The following is a description of a gene set: Any process that stops, prevents, or reduces the frequency, rate or extent of TOR signaling. species: Homo sapiens Human Gene Set: GOBP_NEGATIVE_REGULATION_OF_TOR_SIGNALING, and this is the list of marker genes: PRKACA, SPAAR, ATXN3L, GSK3A (NCBI Gene Id 2931), PRKAA1, ENDOG, UBE2N, DDIT4, ATM, NPC1, KICS2, TSC2 (TSC complex subunit 2), MINAR1 (NCBI Gene Id 23251), OTUD7B, PDCD6, WDR59, RNF167, SAR1A, YWHAZ, UBE3A (NCBI Gene Id 7337), SIRT1, MIRLET7F1 (NCBI Gene Id 406888), BMAL1, SESN2, SEC13, UBE2D1, TBK1, CRYBA1, UBE2W, RNF152, HIF1A, YWHAG, UBR2 (ubiquitin protein ligase E3 component n-recognin 2), SAR1B, AKT1S1, WDR24, NLK, TSC1, ATXN3, EPM2A, PREX1, MIOS, ITFG2, UBR1, PRKAA2, USP7, FLCN, RPS6KA1, SZT2, TNFAIP8L1, PELI1, PRKACB, GSK3B, NPRL3, DEPTOR, FNIP1, MTM1, TBC1D7, SESN1, SAMTOR, MAPK3, CASTOR1, SH3BP4, RPS6KB1 (NCBI Gene Id 6796), MAPKAPK5, PREX2, CASTOR2, NPRL2, TMEM127, KPTN (kaptin, actin binding protein), SEH1L, CASTOR3P, SESN3, STK11, DEPDC5, VHL